Given this list of marker genes ASCC1, FTO, USP9X, MPG (NCBI Gene Id 4350), ASCC2, ASCC3, USP7, ALKBH3, MGMT, ALKBH2, OTUD4 (OTU deubiquitinase 4), here is a description of the gene set: studied in species Homo sapiens The repair of alkylation damage in DNA, e.g. the removal of a non-physiological alkyl group from a nucleobase. This is usually mediated by DNA alkyltransferases. Human Gene Set: GOBP_DNA_ALKYLATION_REPAIR